Given this list of marker genes ITGA1 (integrin subunit alpha 1), ITGB2, RORA, H1-0, LATS2 (NCBI Gene Id 95108), TMEM163, RGS1, S100A10, ATP2B4, IL2RA, KLRC1, KLRC2, IKZF3, GSAP, CYFIP1, SLC39A8, CCL5, BSPRY, CCDC50, HCST, TMEM65, NBEAL2, GZMM, KLRC3, SLAMF7, GNS, PTGES3, MINK1, PRDM1, PRKAR2A (protein kinase cAMP-dependent type II regulatory subunit alpha), EMP3, MARS1, PTPRE, ARF6, TSPAN2, FRRS1, EBPL, IL15RA, PLEKHM3, DSTN (destrin, actin depolymerizing factor), B4GALT5, CYFIP2, GGH, LGALS1, CXCR6, GZMB, MYADM, IFNG, LRRK1, NT5E, HAVCR2, DIPK2A, SNX10, NKG7, CTSW, PROS1, SEMA4A, PIK3AP1, ZFAND4, HIP1, PTPRJ, MYO1F, RNF216, KIF5C, PCGF2, ZEB2, ATP2B1, CALM2 (NCBI Gene Id 805), CYP17A1, ATP6V0D2, SYTL2, KCNJ8, IL18RAP, ABHD5, HLA-B, CTSD, ID2, CISH, CIPC, PTPN13, ELL2, GNPTAB, ANXA1, RAB39B, SRCIN1, STARD10, GNA15, SOAT2, OSBPL3, TNFRSF1B, NFKBIB, ARRDC3, PTGER4, BCL2L1, ITGAL, ERRFI1, ATXN1, S100A6, SH2D1A, KLRK1, BORCS7 (BLOC-1 related complex subunit 7), ERN1, S1PR5, IL12RB2, RUNX2, GIMAP4, ITGAX, SRP68, TNFSF14, BHLHE40, F2RL2, TASL, RHBDF2, IL1RL1, RDM1, PPT1, TBX21, GVINP1, GZMK, CRYBG1, ESM1, CX3CR1, PFKP, NRP1, COBLL1, MYO5A, TTC7B (tetratricopeptide repeat domain 7B), SMPDL3B, DOCK5 (NCBI Gene Id 80005), CERS4, EHBP1L1, SLC4A7, ARSB, IFNAR2, PRF1, ITGA4, CCR2, SMYD3, H2AZ1, FCGR2B, AQP9, L1CAM, IL18R1 (NCBI Gene Id 8809), ANXA2, IL7R, RIPK2, ZDHHC2, UBA6, GABBR1, LAIR1, ARHGAP18, ETFB, EPSTI1, AHNAK, DAPK2, LPIN1, DKKL1, ARL4D, CD44, ARL4C, XDH, ADGRE5, CSF1R, PIK3R5, DMRTA1, AP1G2, EEA1, SEMA4F, CD82, MAPKAPK3, XYLT1, GALNT3, MYLIP, ITGB1 (integrin subunit beta 1), ALCAM, TTC39C, SLC2A3, GIMAP6, LGALS3, RPA2, VIM, here is a description of the gene set: from publication Hammer M, Mages J, Dietrich H, Servatius A, Howells N, Cato AC, Lang R (PMID 16380512) Human Gene Set: GSE3565_CTRL_VS_LPS_INJECTED_DUSP1_KO_SPLENOCYTES_UP species: Homo sapiens Genes up-regulated in spleen from DUSP1 knockout: control versus LPS. Activation of the Mitogen activated protein kinase (MAPK) cascade following Toll-like receptor (TLR) stimulation enables innate immune cells to rapidly activate cytokine gene expression. A balanced response to signals of infectious danger requires that cellular activation is transient. Here, we identify the MAPK phosphatase Dual specificity phosphatase-1 (DUSP1) as an essential endogenous regulator of the inflammatory response to LPS. DUSP1-deficient (DUSP1-/-) bone marrow derived macrophages showed selectively prolonged activation of p38 MAPK and increased cytokine production. Intraperitoneal challenge of DUSP1-/- mice with LPS caused increased lethality and overshooting production of IL-6 and TNF-alpha. Transcriptional profiling revealed that DUSP1 controls a significant fraction of LPS-induced genes, that includes IL-6 and IL-10 as well as the chemokines CCL3, CCL4 and CXCL2. In contrast, the expression of the important mediators of endotoxin lethality, IFN-gamma and IL-12, was not significantly altered by the absence of DUSP1. These data together demonstrate a specific regulatory role of DUSP1 in controlling a subset of LPS-induced genes that determines the outcome of endotoxin shock.